Given this list of marker genes MIR140, TRMT11, ZFP69, RNF10, AQP1, GET1, SDSL, GPSM2, PPTC7, FAM53B, XRCC6, IL17C, PIK3AP1, DIO1, LRWD1, GYPA, CSGALNACT2 (chondroitin sulfate N-acetylgalactosaminyltransferase 2), NPC1 (NCBI Gene Id 4864), DPM3, RTTN (rotatin), APOE, RHOH, KDM4B, TMCC2, FTO, MAGEA3, POFUT1, TAS1R3, FAM131C, DTWD2 (DTW domain containing 2), CTSE, TET3, MGST3, CTNND1, DDIT4, PRKAR2B, IFT57, NUP160, ALAS2, BCL7A, SGSM2, ABCD3 (ATP binding cassette subfamily D member 3), TRAPPC2L, CATSPERB (cation channel sperm associated auxiliary subunit beta, NCBI Gene Id 79820), HCN4, GPR137C, FGFRL1, ACAP3, IP6K1, RTEL1, RAI1, ENTPD7, GNPTG (N-acetylglucosamine-1-phosphate transferase subunit gamma), PF4, GNE, THUMPD2, SEC13, H2BC8, AP3D1, PEX26, IFT140, PHPT1, LPCAT1, ASAH2, DBN1, MPP7, STIMATE, TAB1, SLC12A6, BTNL10P, CTSG, JTB, FBXO5, PCDHB16, AP2A2, FAM117A, CDH16, ADSS1, NUDT11 (NCBI Gene Id 55190), GPR35, NFIA, ABCF1, SPG11, CD5L, CDC45, PNPLA7, GFI1B, ARHGAP23, MNS1, CCNG2, DIP2A, AFG1L, STK11, SOWAHA, TAC1, GAB1, CC2D1B, COG7, WDR91, XYLT1, RREB1, SPATA7, MBOAT2 (membrane bound O-acyltransferase domain containing 2), FBXL20, RHOBTB2, GLYCTK, CCNB2, GTF3C1, ASPH, PPP6R2, AKAP8L, HEMGN, PLEKHO1, ZFAND2B, PIGK, ABCB6, ARFGEF2, ATP1B1, PRTN3, STXBP4, TBCD, GIGYF1, CABLES1, LAMC2, PLAUR (NCBI Gene Id 5329), FBXO38, CREBL2, SEC11A, B3GLCT, PNMA8B, ZC3H12A, ALAD, HIP1R, GPN3, SGSM3, TSPAN4 (NCBI Gene Id 7106), ABCB4, TULP2, ACAP2, SLC22A23, LANCL1, SLC9A6, NINL, GALNS, SEC14L2, FKBP9, TXNDC16, TPRN, GPAT3, TMEM121, DDHD2, RAPGEFL1, RALGPS2, GPX2, SLC37A2, PDE4C, CHRNA6, SLC25A25, CEP70, MRS2, ENPP3 (NCBI Gene Id 5169), SLF2, TRIM2, TMEM86A, here is a description of the gene set: from publication Fu W, Ergun A, Lu T, Hill JA, Haxhinasto S, Fassett MS, Gazit R, Adoro S, Glimcher L, Chan S, Kastner P, Rossi D, Collins JJ, Mathis D, Benoist C (PMID 22961053) Genes down-regulated in CD4 T conv: control versus over-expression of IRF4 and FOXP3. The transcription factor FoxP3 partakes dominantly in the specification and function of FoxP3+ CD4+ T regulatory cells (Tregs), but is neither strictly necessary nor sufficient to determine the characteristic Treg transcriptional signature. Computational network inference and experimental testing assessed the contribution of several other transcription factors (TFs). Enforced expression of Helios or Xbp1 elicited specific signatures, but Eos, Irf4, Satb1, Lef1 and Gata1 elicited exactly the same outcome, synergizing with FoxP3 to activate most of the Treg signature, including key TFs, and enhancing FoxP3 occupancy at its genomic targets. Conversely, the Treg signature was robust to inactivation of any single cofactor. A redundant genetic switch thus locks-in the Treg phenotype, a model which accounts for several aspects of Treg physiology, differentiation and stability. studied in species Homo sapiens Human Gene Set: GSE40274_CTRL_VS_FOXP3_AND_IRF4_TRANSDUCED_ACTIVATED_CD4_TCELL_DN